Given this list of marker genes Cgas, Mavs, Cav1 (caveolin 1, caveolae protein), Ciita, Raet1d, Riok3, Pde12, Flot1, Sting1, Zc3hav1, Nfkb1, Colec12, Rigi, Zcchc3, Dhx9, Pqbp1, Tlr3, Ifnb1, Ifih1, P2rx7, Gria1, Mul1, Ralb, Npm1, here is a description of the gene set: studied in species Mus musculus Mouse Gene Set: GOBP_CELLULAR_RESPONSE_TO_DSRNA Any process that results in a change in state or activity of a cell (in terms of movement, secretion, enzyme production, gene expression, etc.) as a result of a double-stranded RNA stimulus.